Given this list of marker genes PPP1R12C, EIF2AK4, ZDHHC15, PTPRM, STK25, NCAM1, NRP1, SPAG9, RREB1, ALCAM, MAP3K13, GDI1, FGF13, PTEN, ARHGEF25, EDN1, STXBP1, EFNA1, KIAA0319, TWF2, RERE, TPBG, POTEF, ADCY1, APP, BCL11A, LGR6, OPHN1, HMCN2, YWHAH, DNM2, CDH11, SEMA5A, MAP2, PITPNA, KIAA1755, STMN1, SIN3A, ECE1, NRN1L, ITGB1, PPP1R12A (NCBI Gene Id 4659), NR2E1, RET (NCBI Gene Id 5979), STAU2, BDNF, MAPT, ARX, EPHA3, EEF2K, FBXO45, NDN, ROBO1, DVL3, RELN, LRP2, ANK3, GPM6A, OR10A4, NLGN3, MYOT, FSTL4, CTTN, PCDHAC2, SCN1B, TAOK2, LAMB2, HPRT1, FEZ2, NTNG1, NTNG2, ANOS1, PLXNB2, ANO1, ATP9A, NOTCH2, PRDM8, ARK2C, ETV1, CNTN6, KNDC1, NUMB, ULK1, SEMA6C, DVL1, SZT2, XK, SLC25A46, DIP2A, BSG, SPP1, DTNBP1, CRPPA, LRRK2, PPP3CA, CDH1, TRPC6, TTC8, NTF3, RPL24, STK11, EPHA7, EPHB1, PLXNA1, CNTN2, ARHGAP33, PAK3, EPHA5, COL25A1, SLITRK5, NPTX1, SMO, NGEF (NCBI Gene Id 25791), ENPP2, HOXA2, CTNNB1, EFNB1, DAB2IP, LMO4, ZDHHC17, S100B, CNTNAP2, TRPV2, TRPC5, ATL1, EFNA4, KIRREL3, NRXN1, PAK1, TNR, BRSK2, TUBB3, PGRMC1, ADNP, KLK8, NRXN3, RASAL1, NES, RIMS2, LPAR3, OTX2, EPHA4, SYT4, PAK2, RGMA, ARTN (artemin), IFRD1, ABI2, ADCY10, SEMA5B, ADORA2A, SHH (sonic hedgehog signaling molecule), SHTN1, FARP1, RTN4R, NIN, EPHA10, KIF21A, BCL2 (NCBI Gene Id 596), MYO9A, VCL, ACTL8, SLC30A1, SPG21, B4GALT5, CLASP2, SRGAP2, POU4F3, SPG11, NECTIN1, MAP1A, PTPRO, SEMA6A, TRIM46, UBB, GAREM2, SEMA3G, IGSF9, TBR1, MFSD2A, TLX2, WNT3, CC2D1A, SKIL, KEL, CUL7, CORO1B, UCHL1, TRAK1, NEUROG3, SLIT1, DHX36, ADGRB1, SEMA3F, POTEKP, IGF2BP1, UST, SLITRK2, CNTN1, CYFIP2, CD2AP, MYH10, EPHA8, NRP2, PARD3, PPP1R12B, COBL, PTPRS, SULT4A1, POU4F1, FLOT1, NEFL, FOXB1, NPR2, TMEM108, SRC, TRIO, RAC3, DLG4, DDR1, ZNF365, LYPLA2 (lysophospholipase 2), NKX6-1, PACSIN1, FYN, NOVA2, NTF4, MAPK8IP2, PTK7, CHRNA7, SKOR2, ITSN2, TIAM2, TBCE, EGR2 (NCBI Gene Id 1959), SPTBN4, CAPRIN2, KIF5C, CUX2, CDK5R1, NFIB, RUFY3, BTBD3, POU4F2, POTEE, TNFRSF12A, PTPRZ1, SLC9A6, CHL1, CPNE9, SLC39A12, BRSK1, EDN2, CLSTN3, PLAA, SLIT3, KANK1, TOP2B, FLRT1, NOG, SMURF1, NUMBL, PAK6, CPNE1, EPHA6, SHOX2, ITPKA, CNTNAP1, SEMA7A, TUBA1A, NFATC4, MAP6 (NCBI Gene Id 85299), L1CAM (NCBI Gene Id 4268), SLITRK3, NEFH, PHOX2B, CD44, UGT8, LGI1, RAB8A (RAB8A, member RAS oncogene family), NTN3, EDN3, CPNE6, CORO1C, FOXG1, MYPN, MAP4K4, SRCIN1, EVL, CPNE5, NSMF (NCBI Gene Id 349336), SOS1, SIPA1L1, DCC, SCN11A, SPRY3, ISL2, DBN1, TGFB2, TIAM1, CELSR3, ARMCX5-GPRASP2, MCF2, ATG16L1, LRP8, IMPACT, WASF1, EFNA5, ZFYVE27 (zinc finger FYVE-type containing 27), FGF8, MYO16, FGFR2, PLXND1, DRD2, YTHDF1, LAMA2, C9orf72, EMB, WNT7A, SYT1, PAFAH1B1, ISLR2 (immunoglobulin superfamily containing leucine rich repeat 2), MUL1, LHX1, ANAPC2, ARPIN, SEMA4D, ROBO2, CYFIP1, PLXNA4, PTK2, VEGFA, TMEM106B, S100A6, DCLK1, PTCH1, PTPRJ, VASP (NCBI Gene Id 7408), NPTN, DPYSL5, ABITRAM, PSEN1, ABI3, RNF157, WDR47, DRGX, VPS54, FEZF1, BCL7A, NKX2-8, WNT5A, TCTN1, SNX1, SEMA4F, KIFC2, ENAH, UNC5B, TANC2, SEMA6D, VANGL2, TAOK3, TUNAR, NGFR, KLF7, LZTS3, POU3F2 (POU class 3 homeobox 2), RNF6, SYNGAP1, SGK1, TTL, NR4A2, SEMA4B, GSK3B, SHANK3, MEF2A, WEE1, KIDINS220, VAX2 (NCBI Gene Id 25806), SLC11A2, NGF, CFL1, CACNG7, PRKCQ, APLP1, PALLD, EVX1, LZTS1 (leucine zipper tumor suppressor 1), EPHB2, ELAVL4, ATP7A, CCK, NRDC, SPAG6, TSC22D4 (NCBI Gene Id 94778), ABL1, ERBB2, RND2, PICALM, GFRA3, PAX6, PLXNC1, POSTN, PTPRD, SEMA3E, TBC1D24, KIF20B, NDEL1, SHANK1, ADARB1, WASF2, SLITRK6, ACTB, CDKL5, ARHGEF7, RAPH1, GDNF, BMP7, PTPRH (protein tyrosine phosphatase receptor type H), LHX9, RAB3A, PLEKHG4, CSPG5, HECW2, CELSR2, RYK, PRKN, PARP6, ALS2, NFASC, CNTN4, ST8SIA2, LHX4, RIMS1, TNN, SYT17, SLC23A2, CUX1, FLRT3, MEGF8, BCL11B, PLPPR4, WNT7B, VIL1, MAP1B, RTN4 (reticulon 4), NLGN1, ABI1, DSCAM, SMAD4, NELL2, CREB1, ARHGAP35, LMX1A (LIM homeobox transcription factor 1 alpha), RAC1, DAB1, HECW1, PARD6B, ARC, BARHL2, PLXNB3, NBL1, ANKRD27, NOTCH1, LLGL1, WASL, NTN4, SEMA3A, PTPN11, NEDD4L, APOE, MAP2K1, NEO1 (neogenin 1), SEMA3D, NR4A3, MICOS10-NBL1, DVL2, METRN, CHRNB2, NTRK1, DOCK10, FN1, GPRASP3, PLA2G10, OBSL1, CRABP2, BRAF, NTN1, SS18L1, AMIGO1, UNC5A, MYCBP2, IQGAP1, EDNRA (NCBI Gene Id 1909), CHRNA3, BOC, PLEKHO1, WNT3A, OLFM1, MAG, MACF1, NKX2-1, PDPN, SRF, VPS13A, ATP8A2, CNTN5, PQBP1 (NCBI Gene Id 5974, polyglutamine binding protein 1), POTEJ, DIP2B, KIF13B, FZD4, NYAP2, MYO9B, PDLIM5, KIF1A, DLX5, GDF7 (NCBI Gene Id 8873), CDC42, RPS6KA5, MARK2, DOCK7, ATOH1, SSNA1, FEZF2, PPP3CB, DISC1, CTNND2, CDK5, NRCAM, DBNL, B3GNT2, HDAC6, FBXW8, CAMK2B, DSCAML1, KALRN, NEXN, ACTG1, THY1, PAX2, LRRC4C, MOV10, LIMK1, GAP43, EFNB2, SEMA6B, SLITRK1, ARHGAP4, MAP2K2, CDK5R2 (NCBI Gene Id 8941), PACSIN2, SH3GL2, DRAXIN, EPHB6, MT3, AURKA (aurora kinase A), ABLIM1, NTRK3, CCKAR, UNC5D, CNP, EFNA2, GRIP1, RAB10, CHN1, PRKG1, PREX2, PLXNA3, CXCL12, MNX1, CDKL3, RAB21, APLP2, ROBO4, BAIAP2, SLIT2, PRKCA (NCBI Gene Id 5578), ISL1, NRN1, KIF5A, FZD3, ROCK1, PRKCZ, GAS7, PLEKHG4B, DAG1, C12orf57, MAP1S, SIAH1, NDP, VAX1, GLI3 (GLI family zinc finger 3), GORASP1, NTRK2, ARHGAP44, EPB41L3, DCDC2 (doublecortin domain containing 2), ATOH7, SEMA4C, USP33, BMPR2, NEDD4, RAPGEF2, VLDLR, SEMA4A, EMX1, SEMA4G, ZNF335, LRP4 (NCBI Gene Id 4038), POTEI, MDK, CTNNA2 (catenin alpha 2), PTN, NEGR1 (NCBI Gene Id 257194), SPAST, ZEB2, AUTS2, EFNA3, NYAP1, CCDC39, GBX1, ADAM17, EXT1, NOTCH3 (NCBI Gene Id 791), B4GALT6, KIFBP, SNX2, ULK2, EPHB3 (NCBI Gene Id 2049), ARHGEF40, TNIK, CDH4, MINK1, EFNB3, SLITRK4, LHX2, PLXNB1, TRAK2, APBB2, PHACTR1, TSKU, IL1RAPL1, LLPH, SYT2, PRICKLE1, SEMA3B, BMPR1B, ADGRB3, CHODL, SEMA3C, SDC2, FEZ1, NCKAP1L, B4GAT1, UNC5C, UNC13A, RAP2A, PPFIA2, SYT3, MATN2, NCKAP1, FOXD1, GBX2, ITGA1, LHX3, APBB1, AFG3L2, GLI2, IST1, DICER1, ARHGEF28, ITGA4 (integrin subunit alpha 4), GATA3, OSTN, TUBB2B, FLRT2, GOLGA4, CAPRIN1, SYT14P1, SARM1, CSF1R, ACTBL2, USP9X, KIF5B, SPART, ROBO3, here is a description of the gene set: Human Gene Set: GOBP_CELL_PROJECTION_MORPHOGENESIS studied in species Homo sapiens The process in which the anatomical structures of a cell projection are generated and organized.